Given this list of marker genes Adcy10, Slc2a13, Hepacam, Mlc1, Mt3 (NCBI Gene Id 17751), Eif2s1, Slc17a8, Atp1b2, Adgrg1 (adhesion G protein-coupled receptor G1), Aqp4, Gfap, Clcn2, here is a description of the gene set: Mouse Gene Set: GOCC_ASTROCYTE_END_FOOT species: Mus musculus Terminal process of astrocyte abutting non-neuronal surfaces in the brain.